The following is a description of a gene set: from publication Quigley M, Pereyra F, Nilsson B, Porichis F, Fonseca C, Eichbaum Q, Julg B, Jesneck JL, Brosnahan K, Imam S, Russell K, Toth I, Piechocka-Trocha A, Dolfi D, Angelosanto J, Crawford A, Shin H, Kwon DS, Zupkosky J, Francisco L, Freeman GJ, Wherry EJ, Kaufmann DE, Walker BD, Ebert B, Haining WN (PMID 20890291) CD8+ T cells in chronic viral infections like HIV develop functional defects such as loss of IL-2 secretion and decreased proliferative potential that are collectively termed exhaustion1. Exhausted T cells express increased levels of multiple inhibitory receptors, such as Programmed Death 1 (PD-1). PD-1 inhibition contributes to impaired virus-specific T cell function in chronic infection because antibody-mediated blockade of its ligand, Programmed Death Ligand 1 (PD-L1) is sufficient to improve T cell function and reduce viral replication in animal models. Reversing PD-1 inhibition is therefore an attractive therapeutic target, but the cellular mechanisms by which PD-1 ligation results in T cell inhibition are not fully understood. PD-1 is thought to limit T cell activation by attenuating T cell receptor (TCR) signaling. It is not known whether PD-1 ligation also acts by upregulating genes in exhausted T cells that impair their function. Here, we analyzed gene-expression profiles from HIV-specific CD8+ T cells in patients with HIV and show that PD-1 coordinately upregulates a program of genes in exhausted CD8+ T cells from humans and mice. This program includes upregulation of basic leucine transcription factor, ATF-like (BATF), a transcription factor in the AP-1 family. Enforced expression of BATF was sufficient to impair T cell proliferation and cytokine secretion, while BATF knockdown reduced PD-1 inhibition. Silencing BATF in CD4+ and CD8+ T cells from chronic viremic patients rescued HIV-specific T cell function. Thus inhibitory receptors can cause T cell exhaustion by upregulating genes – such as BATF – that inhibit T cell function. Human Gene Set: GSE24081_CONTROLLER_VS_PROGRESSOR_HIV_SPECIFIC_CD8_TCELL_DN species: Homo sapiens Genes down-regulated in comparison of CD8 T cells with progressing HIV infection versus those with controlled HIV infection., and this is the list of marker genes: EID1, TMBIM4, PARD6B, MAST4, OAS2, GART, PTPRJ, AP1S1, UNG, ARPC5, SLAMF7, LRRFIP1, PLSCR1, SLC14A2, XPO7, OAS1, SLCO1B3, TARP, PTPRC, SRPK2, RIDA, ADGRG1, IVD, TMEM187, UBE2L6, RPN1 (ribophorin I), GZMB, GPBP1L1 (NCBI Gene Id 60313), CACNA2D3, DERA (deoxyribose-phosphate aldolase), CPS1, GAN, C1GALT1, OAZ3, ZNF35, GZMH, TKTL1, KEAP1, VOPP1, PPIA, HOMER1, GML, PYCARD, RAP1GAP2, PCOLCE2, TMEM243, TRAC, RSAD2, AFM, MTRF1, IGLV1-44, VPS8, ATG3, TMT1A, STIL, NME6, OAS3, THAP10, CCL23, EIF2AK2, IPP (NCBI Gene Id 3652), DNAI7, IRF9, RDH11, SEMA3E, PLEK, MNDA, CEP15 (NCBI Gene Id 57415), MIS18BP1, ZNF80, STAT1, TRIM5, UBE2C, PRSS23, MTHFSD, CEACAM8, BMX, DHFR, STAP1, RHOA, TNFAIP6, SMC6, MYO1B, DLG3, SNTB2, PARP12, HILPDA, MYL5, GMPS, CHI3L2, TMX1, VRK2, AIM2, EXO1, OCLN, MAVS, JAK2, TRIP10, ABCD2, STX7, TSHR, DSP, IFI44, CEP55, NEAT1, LAIR2, PTGS2, MLANA, POF1B, C4orf19, PPFIBP1, FXYD6, MAGIX, RAB11A, NOL4, CDK2, KIAA0040, EDDM3B (epididymal protein 3B), CD38, IFI6, TTC38, MAB21L2, EIF2S2, MARCHF3, TAS2R4, CYP4F12, MCTP2, PSME2, BATF, CCDC121, RBL1, ZNF695, APOBEC3B, IFI44L, USP18, SHOX2, UBE2W, PLA2G4A, INSR, NODAL, NFAT5, RLN2, PRF1, CASP8AP2, XAF1, USH2A, MYOM2, MYLK, CYP7B1, IQCH, TSBP1, ZNF267, TEP1, FIRRM, DHCR24, INTS9, DGKD, PHF14, RASSF8, PSD3, H2AC6, EAF2, DNAAF2, IFI35, SPIN2A, FOSL1, GASK1B, CFAP45, IFI27 (NCBI Gene Id 3429), RNASEH2A (ribonuclease H2 subunit A), NFASC, IFNAR1, IKZF3, MICA (MHC class I polypeptide-related sequence A), GBP2, HIBCH, RTN3, CDH8, SLC22A8, KLRA1P, RBKS, TRGV5, DDX60, PTPRM, USP53, ATP11A, DOK1, RRM2, LY96, MSX2, N4BP2L2, CLEC2B, CHRNA2, ZNF322P1, FFAR2 (NCBI Gene Id 2867), RPAP3, PGLS